Given this list of marker genes ZNF117, MBTPS2, TSPAN5, ARHGEF9, DCN, EHBP1, RHOBTB3, here is a description of the gene set: Genes down-regulated in normal ductal and normal lobular breast cells. Human Gene Set: TURASHVILI_BREAST_NORMAL_DUCTAL_VS_LOBULAR_DN from publication Turashvili G, Bouchal J, Baumforth K, Wei W, Dziechciarkova M, Ehrmann J, Klein J, Fridman E, Skarda J, Srovnal J, Hajduch M, Murray P, Kolar Z (PMID 17389037) species: Homo sapiens BACKGROUND: Invasive ductal and lobular carcinomas (IDC and ILC) are the most common histological types of breast cancer. Clinical follow-up data and metastatic patterns suggest that the development and progression of these tumors are different. The aim of our study was to identify gene expression profiles of IDC and ILC in relation to normal breast epithelial cells. METHODS: We examined 30 samples (normal ductal and lobular cells from 10 patients, IDC cells from 5 patients, ILC cells from 5 patients) microdissected from cryosections of ten mastectomy specimens from postmenopausal patients. Fifty nanograms of total RNA were amplified and labeled by PCR and in vitro transcription. Samples were analysed upon Affymetrix U133 Plus 2.0 Arrays. The expression of seven differentially expressed genes (CDH1, EMP1, DDR1, DVL1, KRT5, KRT6, KRT17) was verified by immunohistochemistry on tissue microarrays. Expression of ASPN mRNA was validated by in situ hybridization on frozen sections, and CTHRC1, ASPN and COL3A1 were tested by PCR. RESULTS: Using GCOS pairwise comparison algorithm and rank products we have identified 84 named genes common to ILC versus normal cell types, 74 named genes common to IDC versus normal cell types, 78 named genes differentially expressed between normal ductal and lobular cells, and 28 named genes between IDC and ILC. Genes distinguishing between IDC and ILC are involved in epithelial-mesenchymal transition, TGF-beta and Wnt signaling. These changes were present in both tumor types but appeared to be more prominent in ILC. Immunohistochemistry for several novel markers (EMP1, DVL1, DDR1) distinguished large sets of IDC from ILC. CONCLUSION: IDC and ILC can be differentiated both at the gene and protein levels. In this study we report two candidate genes, asporin (ASPN) and collagen triple helix repeat containing 1 (CTHRC1) which might be significant in breast carcinogenesis. Besides E-cadherin, the proteins validated on tissue microarrays (EMP1, DVL1, DDR1) may represent novel immunohistochemical markers helpful in distinguishing between IDC and ILC. Further studies with larger sets of patients are needed to verify the gene expression profiles of various histological types of breast cancer in order to determine molecular subclassifications, prognosis and the optimum treatment strategies.